Given this list of marker genes ENDOG (NCBI Gene Id 2021), MIR17, PAWR, FOXP1, FOXO3, here is a description of the gene set: Human Gene Set: GOBP_POSITIVE_REGULATION_OF_HYDROGEN_PEROXIDE_MEDIATED_PROGRAMMED_CELL_DEATH species: Homo sapiens Any process that activates or increases the frequency, rate or extent of hydrogen peroxide-mediated programmed cell death.